The following is a description of a gene set: studied in species Mus musculus Scavenging by Class A Receptors Mouse Gene Set: REACTOME_SCAVENGING_BY_CLASS_A_RECEPTORS, and this is the list of marker genes: Marco, Msr1, Apob, Apoa1, Colec11, Calr, Masp1, Scgb3a2, Apoe, Hsp90b1